The following is a description of a gene set: The chemical reactions and pathways involving a toxin, a poisonous compound (typically a protein) that is produced by cells or organisms and that can cause disease when introduced into the body or tissues of an organism. studied in species Homo sapiens Human Gene Set: GOBP_TOXIN_METABOLIC_PROCESS, and this is the list of marker genes: FMO1, PRKCE, LCAT, CYP3A5, AS3MT, CYP1A2, N6AMT1, CYP1A1, AKR7A3, CYP1B1, FMO2, UGT1A10, CYP2A13, CYP2W1, CYP3A4, UGT1A7, NFE2L2 (NFE2 like bZIP transcription factor 2), ARL1, CPT1A